The following is a description of a gene set: The lipid bilayer surrounding the vacuole and separating its contents from the cytoplasm of the cell. studied in species Mus musculus Mouse Gene Set: GOCC_VACUOLAR_MEMBRANE, and this is the list of marker genes: Chmp1b, Igtp, Nprl2, Tmem45b, Kxd1, Sphk2 (NCBI Gene Id 97350), Dtx3l (NCBI Gene Id 209200), Slc7a14, Fnip1, Atp6v0b, Plaat3, Slc36a4, Chmp2a, Mapkap1, Tmem203, Tpcn2, H2-Ea (NCBI Gene Id 14968), Mfsd12, Atp6v1c1, Chmp5, Tex264, Rheb, Prmt1 (NCBI Gene Id 80681), Cd1d2, Rragc, Ifitm2 (interferon induced transmembrane protein 2), Atp13a2, Atp6v0a4, Rnf13, Rmc1, Rnasek, Slc39a8, Vmp1, Borcs5, Mfsd8, Elapor1, Tab2, H2-M10.2, Rab2a, Atp6v1g2, Slc7a5, Tm9sf1, Abhd6, Ap1s2 (NCBI Gene Id 68960), Deptor, Atg12, Ulk1, Abcd1, Traf3ip3, Gabarapl2, Vps18, Ifitm1, Ap1b1, Litafd, Slc12a9 (NCBI Gene Id 83704), Laptm4b, Chmp6, Sidt2, Npc1, Bloc1s2, Tmem199 (NCBI Gene Id 97763), Snap29, Ctns, Slc2a6, Nprl3, B2m, Atp6v1h, Snx14, Rnf167, Hpse, Tmem9, Chmp3, Dram2, Slc39a14, Ppt1, Cd63, Vopp1, Vps39, Slc3a1, Kics2, Atp6v1f, Tspan1, Atp6v1g3, Slc38a7, Acp3, Glmp, Dram1, Map1lc3b, Stx7, Slc30a2, Gabarap, Atp6v1b2, Ap1s3, Sort1 (sortilin 1), Tmbim1, Litaf, Sar1b, Vti1b, Tmem150c, Irgm1 (NCBI Gene Id 15944), Clcn7, H2-M10.6, Entpd4, Gfap, Mpeg1, P2rx4, Mtmr2, Slc30a4, H2-Oa, Abcb9, H2-DMa, Tmem163, Vamp8, Thbd, Lamp2, Atp10b, Flcn, Tasl, Pip4p1, Rab12 (RAB12, member RAS oncogene family), Uvrag, Ostm1, Wdfy3, Sh3glb1, Tpcn1, Ncstn, Fcmr, Ffar4, Sppl2a, Tfe3, Wdr59, Chmp4b, Vps13b, H2-Eb1, Ap5m1, Sar1a, Rragd, Tbc1d7, Lmbrd1 (LMBR1 domain containing 1), Atp6v1a, H2-DMb1, M6pr (mannose-6-phosphate receptor, cation dependent), Tm6sf1, Ocln, Gpr137b, Sting1, Atxn3, Slc35f6, Mlst8, Abca3, Vps13a, Atp6v1d, Bloc1s1, Itfg2, Gba1, Tecpr1, Atp6v0e2, Depdc5, H2-M10.4, Nkg7, Abcb6, Cubn, Atp6v1g1, Atp6v0d1 (ATPase, H+ transporting, lysosomal V0 subunit D1), Psen1 (NCBI Gene Id 19164), H2-M5, Sec13, Calcoco2, Gimap5, Syt11 (NCBI Gene Id 99745), Slc29a3, Cybrd1 (NCBI Gene Id 73649), Kif5b, Spns1, H2-Q7, Tsc2, Lamtor3, Plekhm2, Rnf152, Trpm2, Ctsd, Lamtor5 (NCBI Gene Id 68576), Rraga, Clcn3, Oca2, Marchf8, Mcoln3, Lrrc8e, Entpd4b, Cdip1, Grn, Plekhm1, Mitf, Lamtor2, Atg14, Itm2c, Lamp3, Rptor, Slc30a3, Pla2g4e, Lrba, Borcs7, H2-M2, Arl8a, Stx17, Gpr143, Pfpl, Tm4sf5, Mmd, H2-M11, Slc37a3, Atg4b, Slc22a17, Vps33a, Slc11a2, Clcn4, Mcoln1, Uba1, Vps4a, Rilp, Sppl2c, Laptm4a, Spag9, Wipi1, Cyb561a3, Wdr24, Slc66a1, Slc36a3, Acp2, Hsp90ab1, Atp6v1e1, Mtor, Minar2, Atp6ap2, Slc36a2 (NCBI Gene Id 246049), Tmem63a, Slc9b2, H2-K1, Znrf2, Slc17a5, Rnf183, Abcd4, Neu3, Slc36a1, Cln5, Atg9a, Cd164, Chmp2b, Bri3, H2-Ab1, Cln3, Chmp1b2 (NCBI Gene Id 74520), Tcirg1, Vps16, Ccdc115, H2-T22, Chmp4c, Spaar, Ifitm7, Tsc1, Ubxn6, Atp6v0a2, Rab2b, Pip4p2, Rictor, Slc38a9, Slc17a9, Gaa, Vps41, Cd68 (CD68 antigen), Trim23 (tripartite motif-containing 23), Laptm5, Sbf2, Tmem150b, Ap1s1, Tmem74, Rpn2, Irgm2, Tfeb, Stx8, Slc48a1, H2-Ob, Treml4, H2-Q1, Slc15a4, Ap5s1, Cyb561, Ifitm3, Tmem138, Tmem59, Slc49a4, Myo7a, Slc46a3, Gpr137c, Kptn, Vps11, Rb1cc1, Scarb2, Rab7, Prkd1, Sppl2b, Eva1a, Hgsnat, H2-Q2, Clec16a, Atp6v0a1, Marchf9, Meak7, Pld3, Tmem79, Tmem165, Mreg, Vps33b (vacuolar protein sorting 33B), Gabarapl1, Borcs8, Tmem175, Atraid, Arl8b, Hps6, Marchf1, Ap1m1, Neu1, Slc31a2, Chmp7, Lamp5, Rubcnl, H2-Q10, Wdr81, Lamtor1, Szt2, Marchf2, Jmy, H2-Aa, Anxa6, Hps4, Snapin, Hspa8, Abca5, H2-Eb2 (NCBI Gene Id 631971), Slc11a1, Gpr155 (NCBI Gene Id 99360), Slc3a2, H2-DMb2, Ccz1, Gpr137, Atp6v1c2, Lamtor4 (late endosomal/lysosomal adaptor, MAPK and MTOR activator 4), Mcoln2, Mfsd1, Slc15a3, Slc26a11, Tmem9b, Cd1d1, H2-Q6, Vps13c, Pgap6, Map1lc3a, Abca2, Vac14 (Vac14 homolog (S. cerevisiae)), Tmem192, Atp6v0d2, Atp6v1b1, Seh1l, Lamp1, Syt7, H2-M10.1, Sesn2, Atp6v0c, Atg16l1, Klc2, Rragb, Chmp1a, Anxa2, Borcs6, Ap1g1, Fnip2, H2-D1, Lrrc8a (leucine rich repeat containing 8A VRAC subunit A), Tmem106b, Mios (meiosis regulator for oocyte development)